Given this list of marker genes PIK3C2A (NCBI Gene Id 5286), PRDM1, KLF3-AS1, FRMPD1, SIAH3, BCL6, CREB5, RTL3, ADGRB3, LYST, FOXP2, TWIST1 (twist family bHLH transcription factor 1), DRG1, AQP5, TLR1, CILK1, NTN1, SLC44A1, PAQR9, JPT2, LENG9, LMO3, TSPAN13, ANGPTL1, UBE2H, KIRREL3-AS3, MGLL, ITGB6, GFRA1, CHCHD7, HOXA11, EBF2 (EBF transcription factor 2), REEP4, CADM1, PLAG1, MSL3, MLLT3, ATXN7L1, CRIM1, NFIA, POGZ, NRG1, MITF (NCBI Gene Id 7487), LUC7L, CELF4, TGIF1, FZD10, CRH, CHN2, NPVF, SCHIP1, BCL11B (NCBI Gene Id 64919), ASIC2, ATP2A2, NFKBIE, ESRRG, DRD3, TBCC, MYOCD, TMOD4, TPPP3, ZIC5, PHOX2B, KCTD15, SHKBP1, LHX9, UBE3A, ADAMTS14, RUNX1, URI1, FBXO36, HOXB3, KLF3, MACROH2A1, SPATA18, HOXA10, PPFIA2, HTN1, HOXA4, NCDN, IGSF9B, IFNA10, CHD6, DRC3, TEAD1, NEO1, TOM1L2, EIF4G1, CITED2, ID1, SCG3, PPP1CB, IGFBP1, KCNQ5, CDAN1, RBFOX1, XPO4, CNMD, ZBTB22, ID2, HESX1, ZNF423, NR1D1, TXNDC12, ALDH9A1, FBXO11 (F-box protein 11), CCND1 (cyclin D1), DMD, CACNA1D, KCNG3, BAMBI, OTX2, MYO10, CD68, MAB21L2, EN1, SLC10A7, CHST8 (NCBI Gene Id 64377), LBX1, HOXA3, GRM3, TSHZ2, HOXD4, RNF146, NREP, LINC03122, SLC6A14, PF4, ADA, SLIT3, ETV1, RTL9, GOLGA1, ZHX2, IP6K2, TSPAN17, GNRHR, ANKS1B, RIPK4, ZBTB37, IRS4, CYP26B1, MAP4K4, PCDH17, KIRREL3, ZIC3, PRKACB, PHTF2, GABRE, NRAS, NOVA1, NEUROD2, ACACA, ITGA3, FSTL1, PDGFRA, ATOH1, COL10A1, EMSY, H3-3B, ARRB2, SCUBE3, TLX3, SGK1, CNPPD1, MYO1E, C4BPA, TSPYL2, EIF4E (NCBI Gene Id 1977), BMP5, PAMR1, PDZRN4, TIMM8A (translocase of inner mitochondrial membrane 8A), ADTRP, PPARG, NPAS3, RPS6KB1, TCP11L2, ABCA6, CPEB4, ELAVL2, EGR2, GABARAPL1, RUNX1T1, MAGI1, ATP1B4, PRR34, LINC00114, SYT4, NR4A3, UBR1, GNAZ, BEND6, JUP, CYP26A1, ATOH8, RETREG2, COL13A1, SSC4D, TNR, MEF2C, TFR2, FGF14, RBP3, VGLL3, here is a description of the gene set: Human Gene Set: HFH4_01 species: Homo sapiens Genes having at least one occurrence of the motif AWKTGTTTGTTTA in the regions spanning 4 kb centered on their transcription starting sites. This matches the FOXJ1 transcription factor binding site V$HFH4_01 (v7.4 TRANSFAC).